Given this list of marker genes Gzmn, Rnf17, Gm8971, Rcbtb1, Gzmd, Il17d, Mcpt-ps1, Gm9547, Ska3, Btf3-ps18, Rpl13-ps3, Dhrs4, Gm10873, Setdb2, Ap1g2, Cryl1, Mrpl57, Gm6852 (predicted gene 6852), Myh6, Adcy4, Zmym5, Gm9012, Mcpt8, Gzmf, Tssk4, 3110083C13Rik, Ripk3, Gm8996, Tm9sf1, Phf11d, Ltb4r2, Gm41162, Carmil3, 1700129C05Rik, Mhrt, Mir208b, Irf9, Nrl, Nynrin, Gm9022, Phf11, Gm22738, Gm18080, Gm4491, Ltb4r1, Gm19716 (NCBI Gene Id 100503479), Gm48906, Rec8, Emc9, Gm23596, Gm8983, Sap18 (Sin3-associated polypeptide 18), Mphosph8, Gm23593, Fgf9, Cma2, Mir6949, Gm5142, Gm22498, Gm24118, Zfhx2os, Ift88, Ift88os, Mcpt2, Gm33321, Gzmg, Gm25887, Gm46455, Eef1akmt1 (NCBI Gene Id 68043), Gm8963 (predicted gene 8963), A730061H03Rik, Gm26440, Gm5801, Jph4, Nop9, Zfhx2, Thtpa, Nfatc4, Cma1, 1700039M10Rik, Dhrs2, Micu2, Gm18073, Tinf2, Mir3077, Sdr39u1, Phf11b, Fitm1, Gm16973, Ctsg, Gm16573, Ipo4, Cenpj, Pspc1, Mcpt9, Mdp1, Rabggta, Zmym2, Gm24392, 2410022M11Rik, Zdhhc20, Myh7, Gm48200, Gja3, Rnf31, B020004C17Rik, Gm33472, Gm10876, Gm10364, Gzme, Gm4819 (predicted gene 4819), Cbln3, Gm8894, Phf11c, Khnyn, Gm8961, Shisa2, Ngdn, Mcpt1 (mast cell protease 1), Psme2, Nedd8, Psme1, Parp4, Dcaf11, Gm4479, Atp12a, Gmpr2, Gjb2, Xpo4, Cideb, Gm25614, Tgm1, Dhrs1, Lats2, Phf11a, Gm4022, Cab39l, Mcpt4, Cdadc1, Gzmb, Gm22218, Cpne6, Gzmc, Gjb6, Gm29717, Pck2, here is a description of the gene set: species: Mus musculus Mouse Gene Set: chr14C3